The following is a description of a gene set: Human Gene Set: GOBP_GOLGI_TO_ENDOSOME_TRANSPORT The directed movement of substances from the Golgi to early sorting endosomes. Clathrin vesicles transport substances from the trans-Golgi to endosomes. species: Homo sapiens, and this is the list of marker genes: KIF16B, RAB14, MON2, AP4M1, DOP1A, KLHL20, AP1AR, SYS1, VPS13C, CORO7, VPS13A, WIPI1, DOP1B, EPS15, AP2A1, GBF1, SORT1